Given this list of marker genes AXIN1, BLOC1S3, RBM38, SLF2, CDK17, PPP1R15B, DCP1B, GSPT1, STK25, GABRB2, CPD, MIP, EEIG2, EHF, HTR1D (NCBI Gene Id 3352), CDR1, KIAA1671, C19orf44, HIPK3, FAM171B, SCAI, POLR2J3, IQCK, SPOPL, UBE2G1, NDUFB6, KLHL29, FOXO1, PCMT1, HRK, EIF4A1, B4GAT1, PEX13, G3BP2, TCEANC, RAB3B, SLC47A2, CGGBP1, GPATCH2L, EMB, MCOLN2, GRB14 (growth factor receptor bound protein 14), SELENOI, SLC66A1LP, NR4A3, HNRNPA0, RLIM, GPN1, ELF2, ENKUR, AFF4, NKAIN1, SFT2D3, PAN3, LACTB (NCBI Gene Id 84943), RRAGC, POLR2J2, PDGFRA (NCBI Gene Id 5156), YIPF3, TMEM81, SGMS2, ATXN2, NEMF, ZCCHC14, CYBRD1, SMARCC2, CREB5, MARCKSL1, VASP, here is a description of the gene set: Human Gene Set: MIR3691_3P studied in species Homo sapiens from publication Chen Y, Wang X (PMID 31504780) Genes predicted to be targets of miRBase v22 microRNA hsa-miR-3691-3p in miRDB v6.0 with MirTarget v4 prediction scores > 80 (high confidence targets).